The following is a description of a gene set: Mouse Gene Set: GOBP_SNRNA_METABOLIC_PROCESS The chemical reactions and pathways involving snRNA, small nuclear RNA, any of various low-molecular-mass RNA molecules found in the eukaryotic nucleus as components of the small nuclear ribonucleoprotein. studied in species Mus musculus, and this is the list of marker genes: Uspl1, Ell3, Ints12, Cc2d1a (NCBI Gene Id 212139), Ints11, Snapc2, Nop10, Exosc4, Snapc4, Ice2, Larp7-ps, Tut1, Fto, Zcchc7, Exosc5, Exosc3, Ints10, Nhp2, Ints7, Ice1, Myod1, Ell, Exosc10, Rbm7, Mettl4, Exosc2, Ints14, Usb1, Rpap2, Exosc6, Mettl16, Larp7, Ell2, Ints9, Dkc1, Snapc3, Exosc8, Ints6l, Ints5, Toe1, Snapc1, Mepce, Polr3b, Exosc7, Snapc5, Exosc9, Zc3h8, Ints3, Ints6, Ints8, Ints2, Ints1 (NCBI Gene Id 68510), Ints4